Given this list of marker genes SEC14L2, CHST13, SRM, IFITM2, MGAT5B, ARMC12, LY6E, PCYT2, NUDT14, P2RX4, FOLR3, LINC03040, ARL2, IFI6, CDHR1, ADISSP, IGLL5, ROGDI, PLBD2, NPW, CTSW, FCGR1A, JAK3, OLFML2A, TPM2, HBE1, MMP25, LY6G6F-LY6G6D, LTBR, BHMT2, FLYWCH1, TP53I3, DECR2, COL18A1, SHISA4 (shisa family member 4), OBSL1, FNDC4, XYLT2, TSPAN17, PPP6R2, POR, SNX27, PIK3IP1, HPR, CD96, LGALS3BP, TPRN, ITPKC, CAMK2A, IFITM1, CDCA7L, S100A12, TSPAN4, ISG15, PHPT1, ANKRD45, MAOB, KLF1, CMPK2, EME1, FKBP5, SMIM1, IDUA, ZNF496, HPSE, FOLR1, ACACA, PSPN, ABHD14A, NICOL1, SERPINH1, FDXR, CD274, FBXO32, APLP1, IFITM3, RNF213, MIIP, UNC13B, CLN6, SLC25A37, H2AC25, MAPRE3, ACADVL, CACFD1, FAM174C, LPAR2, IL1R2, WFDC1, CERCAM, HERC6, SPINK4, LPIN1, MRPL12, GCKR (NCBI Gene Id 2646), FIBP, IFI27, PALS2, STARD7, KREMEN1, SPATA20, SLC2A1, TXNRD3, MBOAT7, TAPBP, MMP17, MRPL27, SMIM10, RSAD2, FHIP2B, EXOC3L4, ALS2CL, HCFC1R1, NRSN2, FAM83H, LBHD1, METRN, LRP3, ALPL, INSL3, ADGRG3, PRAF2, CRELD1, PFKFB4, NDRG3, MZB1, STAB2, KIFC2, here is a description of the gene set: species: Homo sapiens Human Gene Set: MANNE_COVID19_ICU_VS_HEALTHY_DONOR_PLATELETS_UP from publication Manne BK, Denorme F, Middleton EA, Portier I, Rowley JW, Stubben C, Petrey AC, Tolley ND, Guo L, Cody M, Weyrich AS, Yost CC, Rondina MT, Campbell RA (PMID 32573711) Thrombotic complications in patients with COVID-19 are common and contribute to organ failure and mortality. Patients with severe COVID-19 present with hemostatic abnormalities that mimic disseminated intravascular coagulopathy associated with sepsis with the major difference being increased risk of thrombosis rather than bleeding. However, whether SARS-CoV-2 infection alters platelet function to contribute to the pathophysiology of COVID-19 remains unknown. In this study, we report altered platelet gene expression and functional responses in patients infected with SARS-CoV-2. Strongly upregulated genes from differential gene expression analysis of platelets from 4 ICU patients with SARS-CoV-2 infection as well as 5 healthy donors.